Given this list of marker genes Rps27a, Rhoa, Prkcz, Pard3, Tgfb1, Cgn, Arhgef18, Smurf1, Uba52rt, Ubc, Ubb, F11r, Pard6a, Tgfbr1 (NCBI Gene Id 674605), Tgfbr2, Uba52, here is a description of the gene set: TGF-beta receptor signaling in EMT (epithelial to mesenchymal transition) studied in species Mus musculus Mouse Gene Set: REACTOME_TGF_BETA_RECEPTOR_SIGNALING_IN_EMT_EPITHELIAL_TO_MESENCHYMAL_TRANSITION